The following is a description of a gene set: Mouse Gene Set: GOBP_REGULATION_OF_UBIQUITIN_PROTEIN_LIGASE_ACTIVITY species: Mus musculus Any process that modulates the frequency, rate or extent of ubiquitin protein ligase activity., and this is the list of marker genes: Rps7, Rpl23, Fzr1, Mad2l2, Plk1, Mastl, Bag2, Skp1, Dnm1l, Rpl11, Cdc20, Rpl5, Pten, Ube2srt, Usp44, Epm2a, Cdc14b, Btrc, Cdkn2a, Fbxo5, Ube2s, Mad2l1